Given this list of marker genes Dlst, Fdx1, Dlat, Lipt2, here is a description of the gene set: studied in species Mus musculus part of: Post-translational protein modification This event has been computationally inferred from an event that has been demonstrated in another species.<p>The inference is based on the homology mapping from PANTHER. Briefly, reactions for which all involved PhysicalEntities (in input, output and catalyst) have a mapped orthologue/paralogue (for complexes at least 75% of components must have a mapping) are inferred to the other species. electronically inferred by orthology from the curated human pathway Reactome Pathway: Protein lipoylation